Given this list of marker genes Rap1gds1, Bax, Tgm2, Thada, Bak1, Atp2a1 (NCBI Gene Id 11937), here is a description of the gene set: Any process that decreases the concentration of calcium ions in the endoplasmic reticulum. species: Mus musculus Mouse Gene Set: GOBP_NEGATIVE_REGULATION_OF_ENDOPLASMIC_RETICULUM_CALCIUM_ION_CONCENTRATION